The following is a description of a gene set: from publication Lund R, Aittokallio T, Nevalainen O, Lahesmaa R (PMID 14607935) studied in species Homo sapiens Th1 and Th2 cells arise from a common precursor cell in response to triggering through the TCR and cytokine receptors for IL-12 or IL-4. This leads to activation of complex signaling pathways, which are not known in detail. Disturbances in the balance between type 1 and type 2 responses can lead to certain immune-mediated diseases. Thus, it is important to understand how Th1 and Th2 cells are generated. To clarify the mechanisms as to how IL-12 and IL-4 induce Th1 and Th2 differentiation and how TGF-beta can inhibit this process, we have used oligonucleotide arrays to examine the early polarization of Th1 and Th2 cells in the presence and absence of TGF-beta after 0, 2, 6 and 48 hours of polarization. Genes down-regulated in CD4 T cells activated by anti-CD3 and anti-CD28: TGFB1 and IL-12 (2h) versus IL4 (2h). Human Gene Set: GSE2770_IL12_AND_TGFB_VS_IL4_TREATED_ACT_CD4_TCELL_2H_DN, and this is the list of marker genes: LGALS8, HTRA1, TMEM170B, ZNF652, TRAK1, SLC27A4, PINK1, CEP192, TGS1, DMXL1, MPHOSPH6, MSRA, TRIM23 (tripartite motif containing 23), HOXB2, KLHL9, KCTD11, RAB4A, PIK3R1, DOCK5, FBXO9, RANBP6, MFAP3, CAB39L, TMEM121B, AKAP11, TMEM14C, RNF44, CITED2, FTH1P5, NEK4, ANKRA2, METTL9 (methyltransferase 9, His-X-His N1(pi)-histidine), TULP4, AGO1, NDUFV2, ATG2B, SMCR8, TCEA1, LPCAT1, SPG21, TPST1, CHML, TNRC6B, RNF130, CETN3, GNPTG, BRI3, CD81, TMCO3, CERT1, TAPT1, STRADB, TMEM138, DPY19L1, OIP5-AS1, GSTP1, SPOPL, BRD7, DNAJC19, MDM1, ZBTB44, TBC1D14, FH, THYN1, RGP1 (RGP1 homolog, RAB6A GEF complex partner 1), PPWD1, BTBD9, ZNF615 (NCBI Gene Id 284370), LTA4H, ZNF705G, ING2, GID4, FZD7, KLHL26, IRS2, IPMK, SNX30, ARHGAP35, RALGAPA2, ASAH1, PDE7A, MYC, CYP1B1-AS1, SAT2, CPQ, RPP14, DTYMK, MAPK9, S1PR3, SIRPB2, REX1BD, WFDC21P, MAPK1, ANAPC15, RTN1, PXK, SERINC5, GPR161, TAOK3, CYP27A1, ZZEF1, SOCS7, LINC00954, LRPAP1, MPHOSPH8, SPEN, OR5L2, PIP4P2, LYSET, GMIP, CMTM8, KIDINS220, CDC23, SNUPN, TBL1X, C10orf55, ALKBH7, BABAM1, CHST7, SETD1B, MIB1, NUP155, CRBN, TMEM52B, PHF10, LINC00667, CDKN2AIP, USF2, USF3, PTGER2 (NCBI Gene Id 63381), METTL14 (methyltransferase 14, N6-adenosine-methyltransferase non-catalytic subunit), IDH2, NDUFB2, CWC15, HTT, CYB561D2, TBC1D2 (TBC1 domain family member 2), MCRIP2, JTB, OTUB1, KIAA2013, ARB2A, WDSUB1, MRPL34, RDH11 (NCBI Gene Id 51109), BPTF, GSK3B, PIK3C2A (NCBI Gene Id 5286), GAS2L3, ITPRID2, MUS81, SLC35D1, MMP7, IPO9, TNRC18, WDR37, SERINC3, COLGALT1, CDC40, PBX3, FYN, PGGT1B, BBS10, RNF6, RACGAP1, GPATCH8, GMCL1, ANP32B, KMO, C1orf122, AARS2, C14orf28, EVI5, HIPK2, IL17RA, PDPN, LYPLAL1, RGS19, CHD7, SARAF, HOMER3, SHISA8, ARFGAP3, CERS2, TXLNB, PABIR2, ASB1, HDHD5, YIPF6, MTIF3, SLC49A4, ETFRF1, GASK1B, ALG1, EXOC7, RBL2, VPS37C, PHF21A